Given this list of marker genes Cntnap2, Cntn2, Cntnap1, Epb41l3, Nfasc, here is a description of the gene set: Mouse Gene Set: GOBP_PROTEIN_LOCALIZATION_TO_JUXTAPARANODE_REGION_OF_AXON Any process in which a protein is transported to, or maintained at, the juxtaparanode region of an axon. species: Mus musculus